The following is a description of a gene set: Genes predicted to be targets of miRBase v22 microRNA mmu_miR_6341 in miRDB v6.0 with MirTarget v4 prediction scores > 80 (high confidence targets). Mouse Gene Set: MIR_6341 species: Mus musculus from publication Chen Y, Wang X (PMID 31504780), and this is the list of marker genes: Robo2 (roundabout guidance receptor 2), Hoxb1, Nol4, G3bp2, Npnt, Stx6, Ldaf1, Map3k12, Atg16l1, Epc2, Itpr1, Lrig1, Phf12, Ccdc126, Ddx6, Mex3d, Snapin, Fastk, Cfl2, Mmgt1, Ccny, Rnf38, Rtn1, Abhd3, Stxbp5, Garem1, Thsd7a, Ppp6r1, Smoc1, Pmepa1, Mdm4, Prkd3, Dennd10, Nsd3, Vps29, Cyld (NCBI Gene Id 74256), Sphk2, Pxk (PX domain containing serine/threonine kinase), Tes, Arhgap21, Plekhg5, Emx2, Clcn5, Arap2, Caprin2, Pak6, Cltc, Btf3l4, Btbd7, Pou4f1, Hs3st5, Csnk1g1, Cpeb1, Iqgap2, Gng12, Pgm2l1 (phosphoglucomutase 2-like 1), Fcho2, Kdm2a, Adamts20, Skida1, Dcbld2, Mctp1, Zbtb4, Cast, Slmap, Smoc2, Mfsd6, Med12l, Casd1, Gja1, Esr1, Fut9, Ubl3, Memo1, Ereg, Hprt1, Stim2, Socs5, Appl1, Fermt2 (fermitin family member 2), Lcorl, Ankib1, Jade1 (NCBI Gene Id 99826), Prr14l, Mid1ip1, Stimate, Dnajc24, Tnrc6c, Kcna4, Cmpk1, Tshz1, Smad5, Mdn1, Sbno1, Phf3, Ar, Psd3, Dennd1a, Ston2, Kcnj2, Ark2c, Maf, Btbd3, Acvr1, Mbnl1, Nacc2, Lonrf3, Jmy, Mllt6, Ptp4a1, Mat2b, Bnip2 (NCBI Gene Id 76739), Sulf1, Lrp4, Clip1, Lrp8, Cep170, Wee1, Ldlrad4, Plcb1, Rfx7, Sh3d19, Daam1, Mon2, Dsel, Mphosph9, Ptprg (NCBI Gene Id 71324), Rasd1, Spart, Zfp609, Kbtbd8, Mapk8, Tbl1xr1, Atxn1, Fibin, Lrrtm2, Zfp655, Blcap, Zcchc14, Pik3cb, Snx2, Pparg, Cnot6, Cnot7, Brwd1, Sgcb, Larp4, Neurog1, Usp32, Cds1, Cdk19, Pogz, Impdh1, Rap2c, Tbc1d8, Psd, Heg1, Zmat3, Akap11, Erbin, Lonrf1, Mb21d2, Reps2, Btaf1, Ulk2, Csmd1, Arhgap1, Ube2d2a, Adcy1, Sel1l3, Med15, Abcc5, Tnf (tumor necrosis factor), Fam234a, Tbc1d12, Mybl1, Gpr137c (G protein-coupled receptor 137C), Acbd5, Tgfbr1, Psap, Arhgap12, Klhl20, Naa30 (NCBI Gene Id 75009), Zbtb18, Tbcel, Cd69, Tsc1, Pdgfra, St8sia5, Pcnx1, Acsl1, Fmr1, Acsl4, Akirin2, Spred1, Eda, Chst1, Cbfb, St6galnac3, Miga2, Tspyl2, Zfp11, Smarcd2, Wdfy3, Nckap5, Snip1, Ago1, Tmem250, Mdfic, Nectin3, Spire1, Gpatch8, Atp2b2, R3hdm1, Mecp2, Gon4l, Il25, E2f2, Tet3, Dll1, Snx5, Laptm4a, Socs6, Acer2, Usp8, Gga3, Eogt, Kmt2c, Dgke, Vps37a, Sowahb, Tapt1, Relch, Sybu, Prkaa1, Wnk1, Npepl1, Jarid2, Zfp113, Rab5a, Enpp5, Rnf216, Dpysl2, St18, Elk3, Map3k8, Phaf1, Btg1, Lgalsl, Calm2, Wnt2b, Ago4, Togaram1, Asxl2, Mapk1